Given this list of marker genes Ifitm2, H2-Q2, Chmp2a, Chmp6, Slc17a9, Oca2, Marchf2, Ctsd, Litaf, Tpcn1, Tmem192, Syt11, Rragd, Rnf183, H2-DMa, Abcd4, Rmc1, Borcs7, Znrf2, Tfeb (NCBI Gene Id 21425), Rilp, Acp3, Ap5m1, Dram1, H2-Oa, Sesn2, Wdr24, H2-Q6, Syt7, Sppl2b, Bloc1s1, Tmem203, Clcn7, Trpm2, Rragc, Atxn3, Lamtor5, Mcoln2, Tmem163, Laptm4b, Lamp3, Wdr59, Tmem45b, Ccz1, Marchf9, H2-M10.2, Bloc1s2, Fcmr, Ifitm7, Rab12, Myo7a, Tasl, Atp6v0d1 (NCBI Gene Id 11972), Gpr137, Sting1, Pip4p1, Slc26a11, Itfg2, Mitf, Bri3, Slc30a4, Arl8a, Lamtor3, Atp13a2, Nprl2 (NCBI Gene Id 67232), Tmem175, Flcn, Chmp1b2, Gpr137c, Mtor, Ncstn, Sphk2, Uba1, Tmem59, Ap1b1, Clcn4, Kptn, Cyb561a3 (NCBI Gene Id 76431), Grn, Sec13, Slc39a8, Mfsd1, Slc7a14, Slc37a3, Klc2, Cdip1, Vps41 (VPS41 HOPS complex subunit), Lamp1, Rictor, Slc39a14, Stx8, Wdr81, Slc29a3, Tmem63a, H2-T22, P2rx4, Ap1g1, Mlst8, Gba1 (NCBI Gene Id 14466), Kxd1, Atp6v1g1, Depdc5, Sidt2, Borcs6, Lmbrd1, Ppt1, Slc15a4, Marchf8, Gimap5, Vps39, Psen1, Nprl3, Rnf13, Dram2, Lamp5, Tmbim1, Atp10b, Gpr137b, Chmp7, Marchf1, Slc30a3, Rragb (NCBI Gene Id 406229), Eva1a, H2-DMb2, Vopp1, B2m, Mapkap1, Atg16l1, Abca2, Cybrd1, Chmp4b, Pfpl, Abcb6, Rheb, Tab2, H2-M10.6, Pld3, Tmem106b, Tm6sf1, Chmp5, H2-DMb1, Cd164, Tmem150c, Slc11a2, Borcs5, Tfe3 (transcription factor E3), Mreg, Deptor, Clec16a, Ctns, Vps18, Sppl2a, Tmem74, Vps11, Mios, Sar1a, Pgap6, Spaar, Slc38a7, M6pr, Lamtor1, Glmp, H2-Ab1, Tecpr1, Hsp90ab1, Gpr155, Slc3a2, Arl8b, Scarb2, Itm2c, Sar1b, Clcn3, Traf3ip3, H2-Aa, Lamtor4, Tmem79, Gfap (NCBI Gene Id 14580), Hpse (heparanase), Rraga, Fnip1, Slc36a4, Cubn, Laptm5, Pip4p2, Kif5b (NCBI Gene Id 16573), Slc2a6, Atp6ap2, Stx7, Rnf152, Tpcn2, Mcoln3, Rptor, Mfsd8, Anxa6, Vps33a, Ap1s1, Slc17a5, Seh1l, Slc31a2, H2-Q10, Vps33b, H2-M5, Lrrc8a, Minar2, Vps13a, Snx14, Ubxn6, Cln5, Tm4sf5, Cd68, H2-M11, H2-K1, Sort1, Laptm4a, Abhd6 (abhydrolase domain containing 6), Mcoln1, Ostm1, Hps6, Chmp4c, Tbc1d7, Tmem165, Tspan1, Ifitm3, Vps16, Npc1, Slc48a1, Rnf167, Abca3, Cd1d2, H2-Ob, H2-M2, Lrrc8e, Slc9b2, H2-Eb2, Prmt1, Cln3, Fnip2, Cd1d1, Dtx3l, Plaat3, Spns1 (NCBI Gene Id 73658), Plekhm1, Ffar4, Slc30a2, Hgsnat, Gaa, Pla2g4e, Trim23, Litafd, Slc38a9, Abcd1, Hspa8, Tmem9b, Mpeg1, Chmp3, Ap5s1, Kics2, H2-Q7, Lamtor2, Cyb561, Neu1, Szt2, Sppl2c, Treml4, Rab7 (RAB7, member RAS oncogene family), Entpd4, Acp2, Chmp2b, Vamp8, Slc12a9, H2-M10.1, Neu3 (NCBI Gene Id 50877), Slc11a1, Slc15a3, Mmd, Ap1s3, Gpr143, Meak7, H2-M10.4, Tmem9, Slc7a5, Vti1b, Atraid, Vps13b, H2-Q1, Chmp1b, Slc35f6, Irgm1, H2-Ea, Ap1s2, Snapin, Ap1m1, Elapor1, H2-D1, Slc66a1, Borcs8, Anxa2, Ocln, Lamp2, Tsc2 (NCBI Gene Id 22084), Vps13c, Cd63, Chmp1a, Ifitm1, Tm9sf1, Slc36a1, Abca5, Slc46a3, Abcb9, Spag9 (NCBI Gene Id 77138), Tsc1, Plekhm2, Lrba, Hps4, Nkg7 (NCBI Gene Id 72310), Mfsd12, Slc49a4, H2-Eb1, here is a description of the gene set: The lipid bilayer surrounding a lytic vacuole and separating its contents from the cytoplasm of the cell. Mouse Gene Set: GOCC_LYTIC_VACUOLE_MEMBRANE species: Mus musculus